Given this list of marker genes Rel, Rnf13, Naip1, Cbx5, Urb2, Chic2, Creb5, Dbndd1, Ccdc178, Tpbg, Tspan12, Eml4, Adrb2, Clec4n, Acsl4, Slc38a2, Hnrnpa3, Epc2, Oprk1, Epb41l3, Ct45a, B3gnt2, Plekhm3, Suclg2, Vwa5a, Hoxc4, 4930519G04Rik, Kdm5c, Cnksr2, Cadm1, Magi3, Hecw1, Zic4, Celsr3, Dr1, Clca2, Egr2, Plaa, Nadk2, Eloc, Klrd1, Saa2, E2f2, Lclat1, Azin1, Rad21, Cd2ap, Pik3r3, Ino80d, Ccar2, Lpgat1, Zfp467, Rfx4, Mcm8, Spin1 (spindlin 1), Slc37a2, Tfap2a, Aldh1a3, Vgll1, Ppp6r3, Zdhhc17, Magee2, Nrcam, Lepr, Cfap141, Cwc22, Rab3c, Csnk1g1, Calm1, Itgav, Gria3, here is a description of the gene set: Genes predicted to be targets of miRBase v22 microRNA mmu_miR_345_3p in miRDB v6.0 with MirTarget v4 prediction scores > 80 (high confidence targets). from publication Chen Y, Wang X (PMID 31504780) Mouse Gene Set: MIR_345_3P studied in species Mus musculus